The following is a description of a gene set: Mouse Gene Set: UEDA_PERIFERAL_CLOCK Molecular timetable composed of 162 time-indicating genes (182 probes) in the peripheral (liver) clock. Detection of individual body time (BT) via a single-time-point assay has been a longstanding unfulfilled dream in medicine, because BT information can be exploited to maximize potency and minimize toxicity during drug administration and thus will enable highly optimized medication. To achieve this dream, we created a molecular timetable composed of >100 time-indicating genes, whose gene expression levels can represent internal BT. Here we describe a robust method called the molecular-timetable method for BT detection from a single-time-point expression profile. The power of this method is demonstrated by the sensitive and accurate detection of BT and the sensitive diagnosis of rhythm disorders. These results demonstrate the feasibility of BT detection based on single-time-point sampling, suggest the potential for expression-based diagnosis of rhythm disorders, and may translate functional genomics into chronotherapy and personalized medicine. species: Mus musculus from publication Ueda HR, Chen W, Minami Y, Honma S, Honma K, Iino M, Hashimoto S (PMID 15273285), and this is the list of marker genes: Lpin2, Cyb5b, Adh4, Cldn1, Ak2, Chd4, Rorc, Tle1, Anp32a, Col18a1, Slc2a2, Gpcpd1, Pcsk4, Fbxo21, Ubr3, Elovl5, Cd47, Cyp8b1, Fdx1, Nr1d2, Bhlhe40, Elovl6, Ppp1r3c, Slc11a2, Ubap2l, Cyp7a1, Irf6, Spata13, Chka, Chordc1, Rbpms, Lgals9, Dhcr7, Hnrnpab, Ppara, Aqp8, Erbb3, Il4ra, Rbms1, Nherf1, St3gal5, Gldc, Cnot1, Tmem150a (NCBI Gene Id 232086), Stbd1, Abcb4, Crebrf, Cpt1a, Htatip2, Ethe1, Usp2, Sqstm1 (NCBI Gene Id 18412), Id2, BC004004, Gne, Tsc22d1, Stmp1, H1f2, Hmgcs1, Atl2, Rcl1, Hal (NCBI Gene Id 15109), Nfil3, Atf5, Ift46, Per2, Npc1, Mapk14 (mitogen-activated protein kinase 14), Litaf, Pla2g12a, Tspan4, Fgf1, Asl, Fdps, Btg1, H2bc1, Cry1, Tnfrsf1b, Tubb2a, Kat2b, Cd9, Zfp644, Alcam, Hes6, Lmo7, Tars1, Trip6, Acot1, Tuba1a, Dnaja1, Ptp4a1 (protein tyrosine phosphatase 4a1), Tubb5, Tuba3a, Ak4, Fermt2, Ndrg1, Avpr1a, Crip2, Atxn2, Noct, Dhrs3, Idi1, Mcm10, Hsp90aa1, Oga, Klf9, 1810009A15Rik, Alas1, H6pd (hexose-6-phosphate dehydrogenase (glucose 1-dehydrogenase)), Aqp9, Slc25a47 (solute carrier family 25, member 47), Psen2, Cebpa, Ripor2, Ubxn1, Fasn, Mesd, Ccl9, Pnkd, Pnpla2, Pdia4, St3gal1 (NCBI Gene Id 414082), Slc29a1, Cyp2a4, Serpinf2, Rbm3, Hmgcr, Ifitm6, Herpud1, Col4a1, Chp1, Myorg, Glo1, Irf9, Gclc, Thrap3, Bnip3, Foxa3 (NCBI Gene Id 15377), Galt, Hsph1, Gabarapl1, Bmal1, Cebpb, Nr1d1, Mknk2, Dnajb11, Apoa5, F2r, Slc37a4, Cks2, Lonp2, Upp2, Dynll1, Lsr, Por, Hspa4, Inca1, Fbxo8, Dazap2, S100a10, Bri3, Hsd3b5, Etfbkmt, Tfpi2, Fkbp4, Onecut1 (NCBI Gene Id 52327), Hmgb3, Map2k3, Pnp, Hspa8, Ppdpf, Ces1d